Given this list of marker genes ARL2, SUCLG1, COL6A1, MOSPD1, ECHS1, COL8A2, TMED3, REEP5, SUCLG2, ABHD6 (abhydrolase domain containing 6, acylglycerol lipase), ANKMY2, FAM89B, RAP1GDS1, INTS13, SLC22A5, NNT, EBP, TGFBI, MRM2, MAN1A1, ATP6V0E2, ERP29, CUTA, DPY19L4, IMPA2, HMGN3, GUSB, KIAA0930, COMT, RMDN3, CCDC88A, PRKDC, SLC46A3, PCCB, PHYH, ATP5MC3, UQCRH, MCOLN3, METTL5, TOR3A, LGALS9, GGCT, HLTF (NCBI Gene Id 6596), SLC25A5, VAMP8, CASP6, MTHFD1, MRPS7, CMC4, NDUFS3, ME2, MRPL34, MRPS33, PEPD, BSCL2, RPLP0, WASHC3, ACP5, PHB2, EMC1, TMEM243, ATP5MG, SLC29A3, NFS1, CDK2AP1, ALG8, SLC25A1, SNX24, RAD50, AMZ2, PRDX4, ATP5F1A, MMD, ACAA1, PLD3, ADH5, MTX1, CEBPA, BRCC3, HADHB, ACAT1, TM6SF1, SLC48A1, IDH1, CCDC6, GNAS, HMOX2 (NCBI Gene Id 3163), CHPT1, EPAS1, VAT1, AGL, ABHD2, HDDC2, PPP1R7, MRPS18B, SNRNP25, APEH, ACAT2, HSPB1, MDH1, TEX2, RAP2A, UQCRC2, PCK2, SNX17, DUS4L, DHCR24, STAC, GOT2, COX7B, GPI, WDR12, ALDH2, IDH2, VEGFB, TIMP2, CDK5, DLAT, ATP5MC2, TFRC, TP53I3, PPT1, HEXB, TMEM135, FBP1, HLA-DMA, ABHD10, COX5A, OSBPL9, NDUFB5, SEPTIN11, RASGRP3, PIGK, FEZ2, PEBP1, PTER, ACADM, VCL, SESN1, GTF3A, PRDX6, NR1H3, OSBPL1A, MRPS35, ECH1, HIGD2A, PPIC, APEX1, APOE, TTC3, EIF4EBP1, DENND4C, MGST2, UQCRQ, ITGAE, TGFBR2, PPIA, MAPKAP1, SPARC, HAUS4, MGST3, MRPS27, SEL1L3, CALHM2, TRMT61B, RNH1, MRPS15, SMCO4, CKS1B, SNX5, RPE, ME1, MRPL24, FAM162A, LDHB, ATP5F1B, SCP2, RSU1, DIPK1A, SKIC8, TBC1D5, MTMR1, FDFT1, MPP1, QDPR, PRPS2, AHCY, ESYT1, ITFG1, GLRX5, AIFM1, MPV17, TNFRSF21, MPC1, NDUFA8, POP5, NME1, ACOT13, GPX3, PEX19, here is a description of the gene set: Immune cell-specific expression is one indication of the importance of a gene's role in the immune response. In order to identify such patterns, we set out to broadly profile gene expression in a variety of immune cells. Human Gene Set: GSE22886_DAY1_VS_DAY7_MONOCYTE_IN_CULTURE_DN species: Homo sapiens Genes down-regulated in comparison of monocytes cultured for 1 day versus those cultured for 7 days. from publication Abbas AR, Baldwin D, Ma Y, Ouyang W, Gurney A, Martin F, Fong S, van Lookeren Campagne M, Godowski P, Williams PM, Chan AC, Clark HF (PMID 15789058)